The following is a description of a gene set: species: Homo sapiens Human Gene Set: GOBP_REGULATION_OF_STEROID_HORMONE_SECRETION Any process that modulates the frequency, rate or extent of steroid hormone secretion., and this is the list of marker genes: CYP19A1, GDF9, NKX3-1, C1QTNF1, TAC1, POMC, KDM5B, SPP1 (secreted phosphoprotein 1), PTPN11 (protein tyrosine phosphatase non-receptor type 11), BMP6, DAB2, RETN, CRH, CRY1, GAL, AGTR1, GALR1, KCNK9, TSPO, AGT, GHRL, CRHR1, CRY2, ECRG4, REN